The following is a description of a gene set: species: Homo sapiens Reactome Pathway: Formation of the active cofactor, UDP-glucuronate Glucose 1-phosphate and UTP are the precursors to UDP-glucuronate formation. After oxidation of the resultant complex, UDP-glucuronate is transported to the ER lumen. part of: Glucuronidation, and this is the list of marker genes: UGP2, SLC35D1, UXS1, SLC35D2 (solute carrier family 35 member D2), UGDH